The following is a description of a gene set: from publication Cui A, Huang T, Li S, Ma A, Pérez JL, Sander C, Keskin DB, Wu CJ, Fraenkel E, Hacohen N (PMID 38057668) studied in species Mus musculus Genes negatively differentially expressed in cell type: cDC2 (conventional dendritic cell type 2) upon treatment with cytokine: BAFF in mouse lymph nodes in vivo. Mouse Gene Set: CUI_CDC2_BAFF_RESPONSE_DN Cytokines mediate cell-cell communication in the immune system and represent important therapeutic targets. A myriad of studies have highlighted their central role in immune function, yet we lack a global view of the cellular responses of each immune cell type to each cytokine. To address this gap, the authors created the Immune Dictionary, a compendium of single-cell transcriptomic profiles of more than 17 immune cell types in response to each of 86 cytokines (>1,400 cytokine-cell type combinations) in mouse lymph nodes in vivo. A cytokine-centric view of the dictionary revealed that most cytokines induce highly cell-type-specific responses. For example, the inflammatory cytokine interleukin-1β induces distinct gene programmes in almost every cell type. A cell-type-centric view of the dictionary identified more than 66 cytokine-driven cellular polarization states across immune cell types, including previously uncharacterized states such as an interleukin-18-induced polyfunctional natural killer cell state., and this is the list of marker genes: Ccnl1, Ttc3, Sult1a1, Tnfsf9, Bcl11a, Fos, Tcf4, Pfkfb3, Apod, Dusp1, Nr4a2, Hspa1b, Dab2, Pim1, Jun, Btg2, Lag3, Egr1, Neat1, Zfp36, Coq10b, Fosb, Hspa1a, Stk17b, Atf3, Zfp36l1, Il1b, Trib1, Pmaip1 (NCBI Gene Id 58801), Ppp1r15a, Ier2, Junb, Ptgs2